Given this list of marker genes NSD2, BRIP1, DLG2, PABIR1, UHMK1, NFIC, TRIM21, LYPLA1, RNF39, JPH4, TNS1, DLG1, MTCL2, BAZ2A, HLA-DQA1, SLC35F1 (NCBI Gene Id 222553), TULP4, MTPN (NCBI Gene Id 94351), INO80D, EXOC8, PABIR2, FRZB, ZNF652, RORA, ZBTB39, BAAT, ZBTB44, SOCS6, GFRAL, DNAAF11, LY75-CD302, DSC3, TSC22D4, DTX4, SOX6, FTHL18P, FBXO42, MMADHC, CCNI2, BLMH, AGPAT1, LUZP1, DOCK8, DKK2, IGF1R, NDUFA4, KLRG1, MS4A1, CD302, SGCZ, NAV2, ENDOD1, FCGR1BP, ARHGEF39, IKZF4, MMP11, SLC34A1, GPR65, SSBP2, FUT8, SLC25A13, RCL1, MED18, SLC24A2, ONECUT2, ODF1, RIC3, CHRDL1, DAB2, PSD2, CACNB4, USB1, ANKS1A, CSGALNACT1, SLC25A17, ZDHHC9, TAGLN3, ATG16L2, PDX1, GPR61, GRIN2A, XPO7, CCDC127, RFX5, NAIF1, MYO1D, MTMR11, KAT7, ADAM28, ZFYVE1, RSPO4, COPG2, SNAP25, CALCOCO1, CD59, FAM168A, TAOK2 (TAO kinase 2), IFFO2, FMNL3, CLSPN, KANK2, MS4A13, BASP1, SH3TC2, SH3PXD2A, POU2F2, FIBIN (fin bud initiation factor homolog), CCL13, CNTFR, TREM1, UBXN7, APCDD1, PRKRA, PBX2, RNF44, NCEH1, NRN1, PGR, RHOH, VRK3, PRP4K, TRIM66, FOXJ2, GDF5, RHOA, CDK17, ACSBG2, UBE2QL1, PARP11, CSRP3, PRDM15, FBXO31, SLC25A36, TMED10, ATL2, KIAA1549L, PDPR, PRKCA, WNT1, RTL5, E2F2, ENOSF1, SIX3, PITPNA, POU3F3, KLHL29, PSMD11, GEMIN4, IGF2R, HBP1, PRG2 (proteoglycan 2, pro eosinophil major basic protein), here is a description of the gene set: Human Gene Set: MIR3150B_3P studied in species Homo sapiens Genes predicted to be targets of miRBase v22 microRNA hsa-miR-3150b-3p in miRDB v6.0 with MirTarget v4 prediction scores > 80 (high confidence targets). from publication Chen Y, Wang X (PMID 31504780)